The following is a description of a gene set: studied in species Homo sapiens The ATP-binding cassette (ABC) transporters form a large family of transmembrane proteins that utilise the energy from the hydrolysis of ATP to facilitate the movement of a wide variety of substrates against a concentration gradient across membrane bilayers. Substrates include amino acids, lipids, inorganic ions, peptides, saccharides, peptides for antigen presentation, metals, drugs, and proteins. Of the 48 known ABC transporters in humans, 15 are associated with a defined human disease. part of: Disorders of transmembrane transporters Reactome Pathway: ABC transporter disorders, and this is the list of marker genes: UBC (ubiquitin C), ABCG5, ABCD1, ABCB6, CFTR (NCBI Gene Id 1080), PSMB3, PSMA1, PSMC5, PSMC2, ABCA12 (NCBI Gene Id 3392), PSMA5, ADRM1, ERLIN1, PSMC4, DERL3, PSMB6, PSMC3, PSMB1, ABCG8, ABCC9, SEM1, PSMB4, PSMA7, PSMD11 (proteasome 26S subunit, non-ATPase 11), ABCB11, PSMB7, ABCC2, RNF185, ABCC6, ABCA1, RPS27A, ABCA3, ABCD4, DERL1, PSMA3, OS9 (NCBI Gene Id 10956), UBB, SEL1L, PSMB2, VCP, PSMD14, PSMC6, UBA52, PSMD7, ABCB4 (NCBI Gene Id 5244), PSMD12, PSMD6, RNF5, PSMC1, PSMD2, ERLEC1, PSMD1, KCNJ11, PSMD13, ABCC8, LMBRD1, PSMD8, APOA1, ERLIN2, PSMB5, DERL2, PSMA6, PSMA4, PSMD3, PSMA2